The following is a description of a gene set: Sleep onset insomnia species: Homo sapiens Difficulty initiating sleep, that is, increased sleep onset latency, refers to the condition where it takes 30 minutes or more to fall asleep. Human Gene Set: HP_SLEEP_ONSET_INSOMNIA, and this is the list of marker genes: GNS, CHD8, KMT5B, PRR12, CRY1, FBXO11, PI4K2A